Given this list of marker genes DNM1L, EFEMP1, OPA1, CYP1B1, MYOC, SAMD7, MAG, MECR, here is a description of the gene set: A pale yellow discoloration of the temporal (lateral) portion of the optic disc. studied in species Homo sapiens Human Gene Set: HP_TEMPORAL_OPTIC_DISC_PALLOR Temporal optic disc pallor